The following is a description of a gene set: studied in species Homo sapiens Reactome Pathway: IRE1alpha activates chaperones IRE1-alpha is a single-pass transmembrane protein that resides in the endoplasmic reticulum (ER) membrane. The C-terminus of IRE1-alpha is located in the cytosol; the N-terminus is located in the ER lumen. In unstressed cells IRE1-alpha exists in an inactive heterodimeric complex with BiP such that BiP in the ER lumen binds the N-terminal region of IRE1-alpha. Upon accumulation of unfolded proteins in the ER, BiP binds the unfolded protein and the IRE1-alpha:BiP complex dissociates. The dissociated IRE1-alpha then forms homodimers. Initially the luminal N-terminal regions pair. This is followed by trans-autophosphorylation of IRE1-alpha at Ser724 in the cytosolic C-terminal region. The phosphorylation causes a conformational change that allows the dimer to bind ADP, causing a further conformational change to yield back-to-back pairing of the cytosolic C-terminal regions of IRE1-alpha. The fully paired IRE1-alpha homodimer has endoribonuclease activity and cleaves the mRNA encoding Xbp-1. A 26 residue polyribonucleotide is released and the 5' and 3' fragments of the original Xbp-1 mRNA are rejoined. The spliced Xbp-1 message encodes Xbp-1 (S), a potent activator of transcription. Xbp-1 (S) together with the ubiquitous transcription factor NF-Y bind the ER Stress Responsive Element (ERSE) in a number of genes encoding chaperones. Recent data suggest that the IRE1-alpha homodimer can also cleave specific subsets of mRNAs, including the insulin (INS) mRNA in pancreatic beta cells. part of: Unfolded Protein Response (UPR), and this is the list of marker genes: TSPYL2, HSPA5, GOSR2, KLHDC3, EDEM1, SULT1A3, DNAJC3, ERN1, ZBTB17, SRPRA, SERP1, PPP2R5B, EXTL2, PLA2G4B, TLN1, DNAJB11, DDX11, LMNA, FKBP14, KDELR3, PDIA6, MYDGF, EXTL3, WFS1, SRPRB, SEC31A, SYVN1, GSK3A, ATP6V0D1, PREB, WIPI1, CXXC1, TATDN2, HYOU1, DCTN1, ADD1, HDGF, CUL7, DNAJB9, SSR1, PDIA5, ACADVL, TPP1, ARFGAP1, XBP1, CTDSP2, EXTL1, YIF1A, GFPT1, SHC1